Given this list of marker genes DDX4, POLR2H, MAEL, PIWIL2, POLR2D, POLR2F, HSP90AA1, PIWIL4, MOV10L1, POLR2B (NCBI Gene Id 7890), POLR2I, POLR2C, POLR2L, POLR2K, TDRD12, PIWIL1, ASZ1, TDRD6, POLR2E, MYBL1, TDRD9, POLR2G, POLR2A, POLR2J, PLD6, HENMT1, FKBP6, TDRKH, TDRD1, here is a description of the gene set: studied in species Homo sapiens In germ cells of humans and mice, precursors of PIWI-interacting RNAs (piRNAs) are transcribed from a few hundred sequence clusters, as well as individual transposons, intergenic regions, and genes in the genome. These longer transcripts are processed to yield piRNAs of 26-30 nucleotides independently of DICER, the enzyme responsible for microRNAs (miRNAs) and small interfering RNAs (siRNAs). The initial step in processing long transcripts to piRNAs is cleavage by PLD6 (MitoPLD), which generates the mature 5' end. The cleavage products of PLD6 are bound by either PIWIL1 (HIWI, MIWI) or PIWIL2 (HILI, MILI) in complexes with several other proteins. The 3' end is trimmed by an unknown exonuclease to generate the mature piRNA. PIWIL1:piRNA complexes appear to be involved in post-transcriptional silencing in the cytosol while PIWIL2:piRNA complexes generate further piRNAs from transposon transcripts and other transcripts in the cytosol. Cleavage products from PIWIL2:piRNA may be loaded into either PIWIL2 or PIWIL4 (HIWI2, MIWI2). Loading into PIWIL2 forms a step in a cytosolic amplification loop called the "ping-pong cycle" which yields further PIWIL2:piRNA complexes from cleaved precursor RNAs. Loading into PIWIL4 yields a complex also containing TDRD9 that translocates to the nucleus and directs DNA methylation of cognate loci, causing transcriptional silencing during spermatogenesis. Transcriptional silencing by piRNAs is necessary to limit transposition of endogenous transposons such as L1 elements in the genome. Reactome Pathway: PIWI-interacting RNA (piRNA) biogenesis part of: Gene Silencing by RNA